The following is a description of a gene set: Human Gene Set: MIR143_5P Genes predicted to be targets of miRBase v22 microRNA hsa-miR-143-5p in miRDB v6.0 with MirTarget v4 prediction scores > 80 (high confidence targets). studied in species Homo sapiens from publication Chen Y, Wang X (PMID 31504780), and this is the list of marker genes: ASF1A, MMD, STRN, ZNF626, KPNA1, SUMF1, MIER3, PRP4K (pre-mRNA processing factor kinase PRP4K), PDX1, ERP27, ABHD10, LRCH1, DPH3, STMN1, TEAD1, LAPTM4A, LY9, SATB1, SNX3, ADRA1A, FAM81A, TMEM260, FAM111B, FERRY3, LAMP1, SESN3, USP14, ZNRF2, ADRB1, RAD21, UBE2Q2, PCNX1, CDK14, PPP2CA, TOPORS, ZNF780B, BTN2A2, MAP3K12, BTBD2, HIPK2, MAP3K2, HYCC1, DYRK1A, SGCZ, SPTBN1, SELENOT, ESRRG, PDS5A, TFDP1, SCN5A, MKKS, KCNJ2, TAX1BP1, ISL1, SKIDA1, TPPP, VSNL1, MPHOSPH9, HAS3, NPLOC4, TTC38, CADPS, IKZF2, SLC49A4, DDX3X, THRA, CITED2 (Cbp/p300 interacting transactivator with Glu/Asp rich carboxy-terminal domain 2), THY1, RHOQ, MAT2A, SIX4, ZC3H12C, PTHLH, BSPRY, POLR3D, NELL2, EMC2, FEZ2, ZNF85, HBS1L, MAP3K7CL, NPNT, SACS, MR1, LARP4, CARD10, GPR85, EOGT, ANKRD11, ABCG2, ZNF138, NUAK1, GLCE, RAP2C, CORO2A, HMGA2, HIF1A, CDK12, KDM2B, RORA, C5orf24, ESYT1, RNF44, PTPN4, KIAA0319L, MINDY2, SLC7A2, ELAVL4, CRYBG3, ARID4B, ZNF460, RALGPS1 (Ral GEF with PH domain and SH3 binding motif 1), FMR1 (fragile X messenger ribonucleoprotein 1), TEX2, TFB1M, RAPGEF6, KBTBD2, MAP3K11, WBP11, ZNF493, RAB12, ZBTB18, RC3H1, VWC2L (von Willebrand factor C domain containing 2 like), RBPJ, MAP3K20 (NCBI Gene Id 51784), CASK (NCBI Gene Id 8573), ARL8B, MAP3K4, G3BP2